Given this list of marker genes RIPK1, SCLY, ETFRF1, SEMA4D, RIN2, CDC14B, TMEM243, VPS26C, HPS3, CLIP1, SELL (NCBI Gene Id 6402), EMP3, SESN1, AMPD3, ITGAV, SLC35D2, HVCN1, LTB, SH3KBP1 (NCBI Gene Id 94010), SBDS, SEC24A, CHD2, NCK1, RNH1, CSK, BCAS3, MINDY1, STING1, ENDOD1, MYO1F, GPR160, MANSC1, RNASET2, TTC39B, SIDT1, TMED8, SORD, ITGB8, MYADM, CCS, TASP1, NSUN3, TRIM59, BICRAL, AP3M2, PIK3C2A, GATA1, TM7SF3 (NCBI Gene Id 51768), SEMA4B, ARHGAP15, PDCD4, SLC46A3, MNT, HECA, EPHX1, TAF9B, SLA, IL18, CRLF3, PLLP, CHD9, ZDHHC2, SH2D1A, RAPGEF5, PARP4, C19orf12 (chromosome 19 open reading frame 12), VPS28, NCK2, GIMAP1, C6orf89, CRIP1 (cysteine rich protein 1), FBXO32 (NCBI Gene Id 114907), MMD, KLF16, POU2F2, P2RY10 (NCBI Gene Id 27334, P2Y receptor family member 10), LDLRAP1, SEC11C, MTMR6, PPCS, RNF139, MFSD14A, CRIM1, KLHL6, SLAMF7, IL10, LGALS1, NR1D2, ADAMTSL4, ITGA6 (integrin subunit alpha 6), FUT11, DHRS7, DBP, CSRP2, SLAMF6, TMEM140, YIPF2, RAB35, ST8SIA6, CCPG1, SYNGR2 (synaptogyrin 2), GIMAP4, TSC22D3, SLAMF1, FBXO46, RILPL2, MSRB3, PHC3, CDK2AP2, GNA15, SELPLG, ATP2B1, PPP2R5A, IL4R, RNF19B, PCK2, SNX20, KLF3, TKTL1, FMO5, AKAP7, CD79B, TRIB2, RNPEPL1, PDE4DIP, TTC39C, HSD17B11, PLAAT3, RAB31, AFMID, C2orf42, TAPBPL, CD200R1L, PLCL1, TRABD, NCOA3, RIN3, RIPOR2, DND1, HIPK2, LAMC1, KIF13B, NCMAP, PLCB3, FLI1, PSEN2, CCR10, SP6, MINDY2, ACBD4, BNIP3L, SLC17A9, SEL1L3, IRF1, ZDHHC20, LENG9, POLR3GL, CPM, HERC4, INPP1, CASS4 (NCBI Gene Id 57091), IL6R, AKAP13, COQ8A, ST3GAL5, PBXIP1, ELL3, SARAF, TEC, ICAM1, IFIT1, TBC1D14, SUN2, YPEL3, ZBTB42, S1PR4, OSBPL9, ZNF143, SLC25A33, CC2D2A, ENPP1, HERPUD1, OTULINL (OTU deubiquitinase with linear linkage specificity like), IGF1R, HOPX, OSGIN1, CAPG, GLRX, ARHGAP9 (NCBI Gene Id 84526), RNF216, NAGA, ITGB7, CHPF, EFR3A, SELENOM, ITM2B, SORBS1, RRM2B, NIPAL3, HSPB1, here is a description of the gene set: Human Gene Set: GSE40274_XBP1_VS_FOXP3_AND_XBP1_TRANSDUCED_ACTIVATED_CD4_TCELL_UP The transcription factor FoxP3 partakes dominantly in the specification and function of FoxP3+ CD4+ T regulatory cells (Tregs), but is neither strictly necessary nor sufficient to determine the characteristic Treg transcriptional signature. Computational network inference and experimental testing assessed the contribution of several other transcription factors (TFs). Enforced expression of Helios or Xbp1 elicited specific signatures, but Eos, Irf4, Satb1, Lef1 and Gata1 elicited exactly the same outcome, synergizing with FoxP3 to activate most of the Treg signature, including key TFs, and enhancing FoxP3 occupancy at its genomic targets. Conversely, the Treg signature was robust to inactivation of any single cofactor. A redundant genetic switch thus locks-in the Treg phenotype, a model which accounts for several aspects of Treg physiology, differentiation and stability. Genes up-regulated in CD4 T conv over-expressing XBP1 versus XBP1 and FOX3P. species: Homo sapiens from publication Fu W, Ergun A, Lu T, Hill JA, Haxhinasto S, Fassett MS, Gazit R, Adoro S, Glimcher L, Chan S, Kastner P, Rossi D, Collins JJ, Mathis D, Benoist C (PMID 22961053)